Given this list of marker genes NR1D1 (NCBI Gene Id 9572), LDLR, MIR181C, MIR181B1, TREM2, here is a description of the gene set: species: Homo sapiens Any process that decreases the frequency, rate or extent of astrocyte activation. Human Gene Set: GOBP_NEGATIVE_REGULATION_OF_ASTROCYTE_ACTIVATION